The following is a description of a gene set: The chemical reactions and pathways involving UDP-alpha-D-glucose, a substance composed of alpha-D-glucose in glycosidic linkage with uridine diphosphate. Human Gene Set: GOBP_UDP_ALPHA_D_GLUCOSE_METABOLIC_PROCESS species: Homo sapiens, and this is the list of marker genes: UGP2, ENTPD5, GSK3A, GALT, UGGT1, UGGT2